The following is a description of a gene set: species: Homo sapiens Human Gene Set: GOBP_RESPONSE_TO_OSMOTIC_STRESS Any process that results in a change in state or activity of a cell or an organism (in terms of movement, secretion, enzyme production, gene expression, etc.) as a result of a stimulus indicating an increase or decrease in the concentration of solutes outside the organism or cell., and this is the list of marker genes: ICOSLG, SLC2A1, HSP90AA1, STK39, WNK3, SLC12A5, EFHD1, RPTOR, TLR3, MICU1, USP15, EPO, NINJ1, ZFP36L1, MLC1 (NCBI Gene Id 654039), ATF2, CASP1, ZFAND1, AQP1, BDKRB2, LRRC8C, XRCC6, TRPV4, TSC22D3, SLC12A6, ERRFI1, ABCB1, TSC22D2, BAX, RELB, MLST8, PYCARD (PYD and CARD domain containing), LRRC8A, SCN7A, SCN2A, TRPV3, FBP1, LRRC8D, PKD2, SLC2A4, NLRP3, VPS13A, WNK1, LETM1, RCSD1, TP53, CLN3, PTGS2, CAB39, PLK3, KCNMA1, ATP1A1, LRRC8E, AKR1B1, NFAT5, MTOR, TIFAB, AQP5, TSC22D4, TSPO, RAC1, DDX3X, TNF, OXSR1, MARVELD3 (MARVEL domain containing 3), KMO, PDPK1, MAP2K7, SLC25A23, CAPN3 (calpain 3), PKN1, SST, MAP7, NLK, CLCN2, ITGA2, MYLK, ARHGEF2, SLC4A11, SLC12A2, YBX3, BAD, CASP3, SERPINB6, FXYD2, PAPPA2, MAPK13